Given this list of marker genes CD46, HLA-DRB1, IFNL1, FGL2, IL23R, TNFSF4, IL23A, IL12RB1, BCL6, TSC1, ST3GAL1, PCK1, IL12B (NCBI Gene Id 7907), HLA-DRA, here is a description of the gene set: Human Gene Set: GOBP_IMMUNOLOGICAL_MEMORY_FORMATION_PROCESS Any immunological memory process that can contribute to the formation of immunological memory. species: Homo sapiens